Given this list of marker genes SLC17A7, SLC2A8, CHRM2, RNF216, UNC13D, SNAP91, HLA-DPB1, VAMP7, MYO6, CLTCL1, GGA2, IL7R, FURIN, ABCB4, ATP6V1G2, HLA-DQB2, APOE, HLA-DQB1, EREG, SFTPB, CD9, HIP1R, RAB14, SYT2, ATP6V1B2, ATP6V1C1, SFTPA2, VTI1A, SCARB2, GAK, M6PR, CLRN1, CD3G, RNASEK, SLC32A1, TFRC, GOPC, RASSF9, CLINT1, PHETA1 (NCBI Gene Id 144717), DVL2, VPS41, BCAP31, ADCY8 (adenylate cyclase 8), EPS15, AP1G1, TF, CEMIP, DVL1, SGIP1, DENND1A, AP1M1, VPS18, LDLR, HLA-DRA, LMBRD1, AP1S1, SCAMP1, AP2S1, AVP, AREG, FCHO1, MLC1, TNK2, APOLD1, CRACR2A, TBC1D5, AP3B2, SNX3, CD4 (NCBI Gene Id 920), LRP2 (NCBI Gene Id 4036), STON2, KIAA0319, SFTA3, AP2A1, EGF, EGFR, CD74, VWF, NRGN, SYT9, AP2A2, FCHO2 (NCBI Gene Id 115548), OCRL, HLA-DRB1, RAB12, ATP6V0A1, MYO1E, GAS7 (NCBI Gene Id 8522), IGF2R, TMED9, ATP7A, AP3B1, SNX9, WNT5A, INPP5F, ATP6V1H (ATPase H+ transporting V1 subunit H), MALL, SLC18A2, AP2M1, AP1G2, STEAP2, FZD5, TYRP1, HEATR5B, HLA-DRB4, SFTPA1, APOB, ATP6V1A, VAMP8, STON1, ENTHD1 (ENTH domain containing 1), EPN2, AFTPH, EDN1, NCALD, HAX1, ATP6AP1, ATP6V0C, RAB5A (RAB5A, member RAS oncogene family), VPS33A, ATP6V1F, CLTB, ATP6V1D, DNAJC5, EPN1, FZD4, PICALM, HLA-DRB3, SFTPC, VPS16, SYNRG, SYT11, AP1S2, SORT1, ROR2, ATP6V1E1, CLTA (NCBI Gene Id 63271), CD3D, LDLRAP1 (NCBI Gene Id 81862), HBEGF, BTBD8, VPS33B, FCGR1BP, FZD2, ATP6V0B, CFTR, RAB3A, FCGR1A, VAMP3, GAD1, AVPR2 (NCBI Gene Id 554), HSPA8, ECE1, EPGN, NECAP1, RAB27A, HLA-DPA1, PHETA2, DENND1C, PIK3C2A, SNX18, HLA-DQA1, SYT1, GPR107, AP1B1, VPS11, CLBA1, ATP6V0D1, SH3GL2 (SH3 domain containing GRB2 like 2, endophilin A1), AAK1, SCYL2 (SCY1 like pseudokinase 2), AP2B1, REEP6, DNM2, DAB2, RAB8B, SFTPD, ASTN2, DENND1B, RAB13, DNAJC6, SH3BP4, PANK1, VAMP4, CLVS2, HLA-DQA2 (major histocompatibility complex, class II, DQ alpha 2), FOLR1, ARC, HIP1, WIPI1, RAB35, AP1M2, ATP6V0E2, CPNE6, CLVS1, STX6, NUMB, TGOLN2, AP4B1, AP1S3, VAMP2, CD207, DBNL, GAD2, TMED10, NECAP2, ADRB2, CLTC, BTC, HLA-DRB5, ADAM10, SLC2A4, SLC18A3, CTLA4, RAB27B, MYCBPAP, SPG21, ATP6AP2, RAB8A, SLC18A1, EPN3, ASTN1, TGFA, here is a description of the gene set: Human Gene Set: GOCC_CLATHRIN_COATED_VESICLE A vesicle with a coat formed of clathrin connected to the membrane via one of the clathrin adaptor complexes. species: Homo sapiens